The following is a description of a gene set: Mouse Gene Set: GOCC_ACTIN_BASED_CELL_PROJECTION studied in species Mus musculus A cell projection supported by an assembly of actin filaments, and which lacks microtubules., and this is the list of marker genes: Dnali1, Fmr1, Mcoln3, Cblif, Atp6v1e1, Ptprz1 (protein tyrosine phosphatase receptor type Z, polypeptide 1), Tbc1d10c, Ppp1r9b, Actg2, App, Fchsd2, Angpt1, Dcxr, Gamt, Pjvk, Ctnnb1, Slc27a4, Slc34a2, Foxa1, Otop1, Cdc14a, Clrn2, Kif13b, Fabp2, Piezo2, Baiap2, Atp6v1b2, Muc20 (mucin 20), Ttyh1, Slc4a7, Kcnj10, Pdgfa, Kcnn3, Tspear, Abitram, Cfl1, Scarb1, Slc26a2, Tek, Pdgfra, Ush2a, Erbb2, Itga6, Cd24a, Acta1 (NCBI Gene Id 11459), Mpp1, Zswim6, Spef1, Calb2, Gpm6a, Myo6, Cib2 (calcium and integrin binding family member 2), Unc5c, Slc6a6, Abi1, Minar2, Ngdn, Rufy3, Ephb1, Piezo1, Pdzk1, Whrn, Antxr1, Oxtr, Adgrv1, Stard10, Vcam1, Ermn, Cyfip1, Pls3, Strc, Ppp1r9a, Rapgef3, Tiam2, Jam3, Syne2, Fzd3, Actn2, Dmd, Ly6g6d, Clic5, Osbpl3, Clic4, Palld, Cdhr2, Tbc1d10a, Tenm2, Clca1, Itga3, Lyz1, Arf6, Car2, Pdzd7, Srcin1, Bpifa1, Ush1c, Washc1, Fzd9, Scimp, Acta2, Dock4, Ninj1, Car9, Tmc1, Kptn, Trpc2, Coro1a, Ift20, Enah, Adgra2, Myo1f, Hyal2, Nherf2, Fscn1, Itgb1, Snap25, Farp1, Myo10 (myosin X), Acp3, Cd302, Cdh1, Ceacam1, Fgd4 (FYVE, RhoGEF and PH domain containing 4), Cnp, Lrrc7, Def6, Atp7a, Slc10a2, Cib1, Cdk5, Adcy6, Slc7a11, Actc1, Spata13, Map2, Mtm1, Cbr1b, Akap5, Stx4a, Myo9b, Iqgap2, Prom1, Muc4, Vezt, Myo1g, Prom2, Ripor2, Twf1, Spn, Crp, Ceacam16, Cdhr5, Myo7b, Myo15a, Aoc3, Slc7a8, Pkhd1l1, Inppl1 (NCBI Gene Id 16332), Slc7a5, Rhoc, Ube2k, Myo3b, Utrn, Fscn2, Ap2a1, Icam2, Apbb1, Ube2q1, Elmod3, Src, Pvalb, Itgb3, Dync1h1, Nedd4, Cubn, Vil1, Wwox, Amn, Espn (NCBI Gene Id 56226), Cbr1, Aqp5, Cftr, Pls1, Ocm, Nos1ap, Crb1, Gap43, Trpv4, Clrn1, Ankrd24, Lcp1, Fmn2, Cdh23, Mttp, Akr1b1, Eps8l2, Pafah1b1, Tubb3, Ceacam20, Homer2, Atp6v1a, Fgf13, Triobp (TRIO and F-actin binding protein), Myo1h, Calb1, Dag1, Shtn1, Anks4b, Nf2, Myo1d, Grxcr1, Exoc4, Atp6v1b1, Myo1e, Enpp7, Kitl, Lipc (NCBI Gene Id 15450), Myo3a, Dpep1, Rdx, Morn4, Ctsl, Dync2i2, Tgfb1, B4galt1, Nherf1, Ptprh, Fscn3, Plekhg6, Msn, Myo1b, Ezr, Eps8, Epha4, Twf2, Npcd, Loxhd1, Lrrk2, Espnl, Pdpn, Atp8b1, Abi3, Vasp, Myo5a, Fat1, Slc38a4, Myo7a, Dbn1, Igf2bp1, Cd44, Podxl, Calml4, Ptprq, Nlgn1 (neuroligin 1), Abi2, Muc17, Lyz2, Bbs2, Itgav, Cdc42, Dlg1, Tprn, Grxcr2, Pcdh15, Nfasc, Myo1a, Palm, Tmc2, Amn1, Lhfpl5 (lipoma HMGIC fusion partner-like 5), Cxadr, Myo1c (NCBI Gene Id 97728), Arl4c